Given this list of marker genes POTEE, ARHGAP12, PIK3R1, BASP1 (brain abundant membrane attached signal protein 1), SYDE1, ACTN1, BAIAP2L1, TMPO, SNAP23, BAIAP2L2, STEAP3, VANGL1, SENP1, ARHGAP39, RAB7A, PIK3R2, DIAPH1, SLC4A7 (NCBI Gene Id 9497), ACTB, ARHGAP21, DIAPH3, ESYT1, ADD3, ARHGAP32 (Rho GTPase activating protein 32), SRGAP2, FARP1, DEPDC1B, DIAPH2, ARHGAP1, LMNB1 (lamin B1), SOWAHC, ARHGAP5, RHOF, AKAP12, MYO9B, CAV1, CAPZB, MCAM, FAM169A, MTMR1, VAMP3, TOR1AIP1, here is a description of the gene set: part of: RHO GTPase cycle studied in species Homo sapiens This pathway catalogues RHOF (RIF) GTPase activator proteins (GAPs) and RHOF effectors. RHOF GTPase is thought to exist in the active GTP-bound state in the absence of any GEF activity. No GDP dissociation inhibitors (GDIs) have been shown to interact with RHOF. RHOF is only found in vertebrates. RHOF regulates cytoskeletal dynamics and promotes the formation of filopodia and stress fibers. RHOF may be involved in actin remodelling in lymphocyte microvilli. In neurons, RHOF contributes to the formation of dendritic spines. Reactome Pathway: RHOF GTPase cycle